The following is a description of a gene set: Signaling by Interleukins species: Homo sapiens Human Gene Set: REACTOME_SIGNALING_BY_INTERLEUKINS, and this is the list of marker genes: TIMP1, IL1A, TALDO1, NKIRAS2, RPS6KA3, STAT2, STAT6, IFNL2, PELI1, IL1B, LCN2, IL1R2, PSMA2, IL1RN, PSMD11 (proteasome 26S subunit, non-ATPase 11), VAMP2, IL17RB, CD4, CTSG, SOS1, PTPN11, UBC (NCBI Gene Id 7316), IRAK1, IL24, HSPA9, H3C14, PTPN2, IL32, BCL2L1, PSMC4, RHOU, SDC1, BTRC, ALOX15, PSMC3, TP53, IL12B, PSMC5, CCL3, CRLF1, CRK, PTPN13, ICAM1, PRKACA, IRF4 (interferon regulatory factor 4), PSMD3, ADRM1, BRWD1, FSCN1, IFNLR1, SMARCA4, PTPN14 (protein tyrosine phosphatase non-receptor type 14), HSPA8, IL34, H3C11, N4BP1, NANOG, TEC, YES1, SOCS1, IL23R, AGER, IL11RA, IL33, LGALS9, MAP2K3, IL7, PDCD4, IL9R, IRS2, NOD1, FBXW11, IL15RA, IL1R1, IGHG4, RPS6KA5, IL2, MAPK14 (mitogen-activated protein kinase 14), H3C1, GSTO1, IL10RB, ITGAM, LAMA5, CASP3, MAP2K1, DUSP6, FN1, PSMA4 (NCBI Gene Id 5685), UBA52, IKBIP, PSMB6, IL17RE, GSTA2, STAT1, PSMD6, BATF, IL22RA2, CSF3R, SNRPA1, CXCL1, CSF3, H3C13, OPRD1, PELI2, PIK3CB, PPP2R5D, PSMA6, HNRNPA2B1, IL17A, IL16, CCL5, PTPN12, IL12RB1, HNRNPF, RAP1B, IL17RC, STX4, FYN, IL2RB, BCL2, CSF2RA, CCL20, MAPK7, ITGB2, CCR2, SOCS5, MAPK8, IL10RA, AKT1, NOD2, IL3RA, CCL4, PTPRZ1, MMP1, IL4, PSME2, ITGAX, PIM1, UBE2V1, LMNB1, PELI3, IFNL3, CCR5, IL27RA, AIP, CD80, S1PR1, H3C2, MAP2K6, MYD88, PTK2B, BCL6, IL20RB, LBP, TAB3, IL10, PPP2R1B, SERPINB2, IL36G, ANXA2, LYN, CCL3L3, USP14, CCND1, SEM1, JAK2, PPIA (peptidylprolyl isomerase A), IL1RAPL1, PSMA3 (proteasome 20S subunit alpha 3), RBX1, PSMB2, STX3, BIRC5, MMP9, ELK1, IL3, GATA3, JUNB, IL36B, USP18, ALPK1, IL19, IGHG1, VIM, SYK, TNF, H3C7, NDN, TNFRSF1B, SIGIRR, CBL (NCBI Gene Id 867), CFL1, PSMD1, RELA, RORC, LIFR, PSMA7, MCL1, SKP1, CCL2, IL11 (interleukin 11), IL20RA, MAP2K4, CDKN1A, PSMB5 (proteasome 20S subunit beta 5), MAPKAPK2 (NCBI Gene Id 9261), UBE2N, CRKL, IL20, IL21, PITPNA, IL17RA, MEF2C, IL6ST, TIFA, PSMC1, SMAD3, FASLG, IFNL1, PSMD13, IL31, CASP8, MAPK1, P4HB, LIF, GRB2, CAPZA1, CDC42, CCR1, PIK3CD, HIF1A, TAB1, PIK3R2, FOS, PTPN5, H3C15, DUSP4, TXLNA, STAT5A, UBB, TRAF6, CXCL8, MAPKAPK3, IL37, PSMA1, IL18RAP, CLCF1, IL6, ANXA1, VEGFA, HMOX1, CSF2, CSF1R, RORA, NLRC5, IL25, HSP90B1, PSMB7, IL36A, DUSP7, OSM, MYC, IGHE, MAP2K7, H3C3, MAP3K7, IL6R, ATF2, RIPK2, JAK1, FCER2, IL1RL2, STX1A, PSMD14, PSMA5, ALOX5, PPP2CB, IL26, CXCL10, SAA1, STAT3, SOD1, MAPK11, PIK3R1, PTPN9, FOXO1, VAV1, IL13, CUL1, IL18BP, ARF1, PSMD12, FOXO3, PTPN20, PAK2, NFKB1, IKBKG, JUN, MAPK3, CCL22, FGF2 (NCBI Gene Id 2247), SOD2, ITGB1, PTPN7 (protein tyrosine phosphatase non-receptor type 7), IL2RG, VCAM1, H3C4, STXBP2, NFKBIB, MIF, MEF2A, PTPN4, NFKB2, EBI3, IL5, APP, NLRX1, MMP3, IL1RL1, POMC, SOX2, CCL19, IL27, H3C10, RPLP0, IRAK2, PSMB4, PSMB3, IL31RA, PPP2R1A, LCK, PSMB1, IL18, IL5RA (interleukin 5 receptor subunit alpha), RPS6KA1, CA1, CREB1, BOLA2, CSF1 (colony stimulating factor 1), TAB2, LCP1, ZEB1, STAT5B, IL36RN, CEBPD (NCBI Gene Id 1052), MUC1, TOLLIP, IRAK4, TNFRSF1A, IL12A (interleukin 12A), MAP3K8, CISH, RPS6KA2, INPPL1, HNRNPDL, PTPN23, INPP5D, SOS2, PIK3CA, SOCS3, CD86, PSMD7 (NCBI Gene Id 5713), IL7R, PSMD2, YWHAZ, H3C12, CCL11, S100B, POU2F1, IL15 (NCBI Gene Id 3600), CASP1, PRTN3, TWIST1, RALA, MAOA, PTAFR, RPS27A, BLNK, H3C8, MSN, TNIP2, CANX, BOLA2B, TBK1, HSP90AA1, HAVCR2, SHC1, ATF1, CXCL2, CNTF, IL1F10, TSLP, SOCS2 (suppressor of cytokine signaling 2), MAPK9, GAB2, RAG1, NFKBIA, CNN2, FPR1, IL22, CRLF2, TGFB1, PIK3R3, MAPK10, IL12RB2 (interleukin 12 receptor subunit beta 2), IRAK3, IL13RA1, IL21R, H3C6, IFNG, PTPN6, CD36 (NCBI Gene Id 948), OSMR, TCP1, RAG2, JAK3, IL4R, HGF, LRRC14, IL13RA2, IL22RA1, PSMD8, NKIRAS1, OPRM1, VRK3, COL1A2, CSF2RB, PTPN18, IL18R1, VAMP7, F13A1, PTGS2, IL1RAP, MMP2, CHUK, IKBKB, CTF1, HCK, SQSTM1, IL2RA, IL17F, IL17C (interleukin 17C), HMGB1, STAT4 (signal transducer and activator of transcription 4), IL23A, RAPGEF1, IL9, SNAP25, GSDMD, MAP3K3, CNTFR, PSMC2, TYK2, S100A12, TRAF2 (TNF receptor associated factor 2), PPP2CA, DUSP3, NOS2, MTAP, PSMC6, IRS1